The following is a description of a gene set: Transforming growth factor beta (TGF-beta) and platelet-derived growth factor A (PDGFAlpha) play a central role in tissue morphogenesis and repair, but their interplay remain poorly understood. The nuclear factor I C (NFI-C) transcription factor has been implicated in TGF-beta signaling, extracellular matrix deposition, and skin appendage pathologies, but a potential role in skin morphogenesis or healing had not been assessed. To evaluate this possibility, we performed a global gene expression analysis in NFI-C(-/-) and wild-type embryonic primary murine fibroblasts. This indicated that NFI-C acts mostly to repress gene expression in response to TGF-beta1. Misregulated genes were prominently overrepresented by regulators of connective tissue inflammation and repair. In vivo skin healing revealed a faster inflammatory stage and wound closure in NFI-C(-/-) mice. Expression of PDGFA and PDGF-receptor alpha were increased in wounds of NFI-C(-/-) mice, explaining the early recruitment of macrophages and fibroblasts. Differentiation of fibroblasts to contractile myofibroblasts was also elevated, providing a rationale for faster wound closure. Taken together with the role of TGF-beta in myofibroblast differentiation, our results imply a central role of NFI-C in the interplay of the two signaling pathways and in regulation of the progression of tissue regeneration. Human Gene Set: PLASARI_TGFB1_SIGNALING_VIA_NFIC_1HR_UP studied in species Mus musculus Genes up-regulated after 1 h of TGFB1 stimulation in MEF cells (embryonic fibroblast) with NFIC knockout vs wild type MEFs. from publication Plasari G, Calabrese A, Dusserre Y, Gronostajski RM, McNair A, Michalik L, Mermod N (PMID 19752192), and this is the list of marker genes: CYP51A1, FOXG1, EVI2A, KCNN4 (NCBI Gene Id 3783), ZFHX3, RBP1, EPHB2, CALCRL, RPL39L, TATDN2, OXCT1, IL2RG, IDI1, NR4A2, DSE, MEOX1, ENPEP, CCN3, MFAP4, FLT1 (fms related receptor tyrosine kinase 1), KCNAB1, PDP1, RAB39B, IFITM3, FLI1, TENT5C, CCR5, GSDME, AHR, PDGFRA, CA6, INSIG1, VWA5A, SOAT1